Given this list of marker genes Stra6, Greb1l, Errfi1, Wnt7a (wingless-type MMTV integration site family, member 7A), Wnt9b, Esr2, Rbp4, Tgfb2, Lhcgr, Cited2, Hoxa9, Cdh1, Lhx1, Foxl2, Fshr, Smad4, Myocd, Col6a1, Hoxa11, Cyp19a1, Src (Rous sarcoma oncogene), Ash1l, Itih5, Kdm5b, Cdkn1c (cyclin dependent kinase inhibitor 1C), Wnt5a, Hoxa10, Gata3, Esr1, Nipbl, Antxr2, here is a description of the gene set: species: Mus musculus Mouse Gene Set: GOBP_UTERUS_DEVELOPMENT The reproductive developmental process whose specific outcome is the progression of the uterus over time, from its formation to the mature structure.